Given this list of marker genes GPX4, STIL, BRD8, FOXM1, KIF2C, CDKN3, SPAG5, SMC4, MCM2, HMGB2, KIF22, STMN1, MYRF, NCAPH, MKI67, PTP4A3, MCM3, POLD1, CHAF1A, CDK1, CCNA2, ZWINT, TPX2, H2AX, PCLAF, CHEK1, TK1, EIF5, CDC6, KIF11, CENPA, NASP, CDC20, PLK1, MCM4, TRAIP, SMC2, GNAI1, RAD51C, DUT, MCM7, MYBL2, SPC25, GALE, PLOD2, SBNO2, CCNB2, HMGA1, PCNA, PLK4, UBE2C, GINS1, CHEK2, TOP2A, CSE1L, CCNB1, AURKB, RFC3, AURKA, BUB1B, SNRPA1, TRIP13, WEE1, APOBEC3B, POLD3, PTTG1, CDC25C, CKS1B, OIP5, NDC80, here is a description of the gene set: studied in species Homo sapiens ANBL-6, a myeloma cell line, proliferates in response to interleukin 6 (IL-6) stimulation, coculture with bone marrow stromal cells, and when harboring a constitutively active mutant N-ras gene. Eighteen samples, including 4 IL-6-treated, 3 mutant N-ras-transfected, 3 normal stroma-stimulated, 2 multiple myeloma (MM) stroma-stimulated, and 6 untreated controls were profiled using microarrays interrogating genes. Global hierarchical clustering analysis distinguished at least 6 unique expression signatures. Notably, the different stimuli altered distinct functional gene programs. Class comparison analysis (P =.001) revealed genes (54% involved in cell cycle) that distinguished IL-6-stimulated versus nontreated samples. Eighty-seven genes distinguished stroma-stimulated versus IL-6-treated samples (22% encoded for extracellular matrix proteins). A total of genes distinguished N-ras transfectants versus IL-6-treated samples (26% involved in metabolism). A total of genes, 20% of these involved in signaling, distinguished N-ras from stroma-interacting samples. All 3 stimuli shared genes, mostly of metabolic function. Genes that distinguished MM1 from MM4 clinical groups were induced at least by one treatment. Notably, only genes (ETV5, DUSP6, and KIAA0735) are uniquely induced in mutant ras-containing cells. We have demonstrated gene expression patterns in myeloma cells that distinguish an intrinsic genetic transformation event and patterns derived from both soluble factors and cell contacts in the bone marrow microenvironment. Genes down-regulated in ANBL-6 cell line (multiple myeloma, MM) expressing a constantly active form of NRAS off a plasmid vector compared to those grown in the presence of IL6. Human Gene Set: CROONQUIST_NRAS_SIGNALING_DN from publication Croonquist PA, Linden MA, Zhao F, Van Ness BG (PMID 12791645)